The following is a description of a gene set: Human Gene Set: GOBP_RESPONSE_TO_LIGHT_INTENSITY Any process that results in a change in state or activity of a cell or an organism (in terms of movement, secretion, enzyme production, gene expression, etc.) as a result of a light intensity stimulus. species: Homo sapiens, and this is the list of marker genes: GNAT2, FRMPD1, SLC24A1, GNB5 (NCBI Gene Id 82962), RHO, EXT1 (NCBI Gene Id 3966), KCNC1, SCN11A, SLC24A4, SLC24A2, AKT2, GNAT1, RDH13, MT-ND3, RGS9, PRPH2, GPSM2, CAT, KCNC2